Given this list of marker genes MATN3, POU1F1, DYM (NCBI Gene Id 54808), DUOX2 (dual oxidase 2), RNU4ATAC, ARSL, KIAA0586, TSHB, PROP1, UFSP2, COMP, SLC5A5, B3GALT6, LHX4, TG, COL2A1, SLC26A2, LHX3, FLNB, HESX1, TSHR, CSPP1, TPO, IYD, DUOXA2, here is a description of the gene set: species: Homo sapiens Human Gene Set: HP_ABNORMAL_OSSIFICATION_INVOLVING_THE_FEMORAL_HEAD_AND_NECK Abnormal ossification involving the femoral head and neck